The following is a description of a gene set: species: Mus musculus electronically inferred by orthology from the curated human pathway Reactome Pathway: FGFR3 ligand binding and activation part of: Signaling by FGFR3 This event has been computationally inferred from an event that has been demonstrated in another species.<p>The inference is based on the homology mapping from PANTHER. Briefly, reactions for which all involved PhysicalEntities (in input, output and catalyst) have a mapped orthologue/paralogue (for complexes at least 75% of components must have a mapping) are inferred to the other species., and this is the list of marker genes: Fgf1, Fgf4, Fgf5, Fgf23, Fgf16, Fgf2, Fgf17, Fgf20, Fgf8